Given this list of marker genes Itpka, Itpk1, Itpkc, Itpkb, Ipmk, here is a description of the gene set: Mouse Gene Set: GOMF_INOSITOL_TRISPHOSPHATE_KINASE_ACTIVITY species: Mus musculus Catalysis of the reaction: inositol trisphosphate + ATP = inositol tetrakisphosphate + ADP + H+.